The following is a description of a gene set: part of: Neurotransmitter release cycle Serotonin is synthesized in the serotonergic neurons in the central nervous system and the enterochrommaffin cells of the gastroinetstinal system. Serotonin is loaded into the clathrin sculpted monoamine transport vesicles. The vesicles are docked, primed and release after the change in the membrane potential that activates voltage gated calcium channels and the reponse by several proetins to the changes in intracellular Ca2+ increase leads to fusion of the vesicle and release of serotonin into the synapse. Reactome Pathway: Serotonin Neurotransmitter Release Cycle studied in species Homo sapiens, and this is the list of marker genes: SYN2, RAB3A, TSPOAP1, CPLX1, SYN1, RIMS1, PPFIA1, PPFIA2, SYT1, SYN3, VAMP2, SNAP25, PPFIA3, SLC18A2, UNC13B, STX1A, STXBP1, PPFIA4